Given this list of marker genes HPGD (NCBI Gene Id 3248), ALOX5, GPX4, LTA4H, here is a description of the gene set: species: Homo sapiens Reactome Pathway: Biosynthesis of D-series resolvins part of: Biosynthesis of DHA-derived SPMs The D-series resolvins (RvD1-6) are biosynthesised from the precursor ω-3 fatty acid docosahexaenoic acid (DHA), either via aspirin-triggered cylcooxygenase catalysis (17(R) AT-RvDs) or via the lipoxygenase pathway (described here) forming the epimeric 17(S)-RvD1-6 resolvins.